Given this list of marker genes IL2RG, STAT5B, JAK3, IL9R, STAT3, JAK1, STAT5A, STAT1, IL9 (interleukin 9), here is a description of the gene set: Human Gene Set: REACTOME_INTERLEUKIN_9_SIGNALING species: Homo sapiens Interleukin-9 signaling